Given this list of marker genes Psmc5, Pthlh, Adcyap1, Gphb5, Ptpn11, Ucn, Lep, Gria1, Gnao1, Crh, Gnas, Ucn2, Gpha2, Gnrh1, Jak2, Ucn3, Fyn, Pth, Ghrh, Vip, here is a description of the gene set: Mouse Gene Set: GOMF_PEPTIDE_HORMONE_RECEPTOR_BINDING studied in species Mus musculus Binding to a receptor for a peptide hormone.